Given this list of marker genes ARF6, GOPC, LEPROT, NEDD4L, SNX33, COMMD1, ACTN2, TAX1BP3, GPM6B, PICALM, ASTN2, CAV3, here is a description of the gene set: Any process that stops, prevents, or reduces the frequency, rate or extent of protein localization to the cell surface. studied in species Homo sapiens Human Gene Set: GOBP_NEGATIVE_REGULATION_OF_PROTEIN_LOCALIZATION_TO_CELL_SURFACE